Given this list of marker genes FGFR3, FGF10, FGFR2, CILK1, SETBP1, FREM2, PRRX1, GLI3, NEK1, SF3B4, here is a description of the gene set: Human Gene Set: HP_HYPOPLASIA_OF_THE_EPIGLOTTIS studied in species Homo sapiens Hypoplasia of the epiglottis Hypoplasia of the epiglottis.